The following is a description of a gene set: Transport of Mature Transcript to Cytoplasm studied in species Homo sapiens Human Gene Set: REACTOME_TRANSPORT_OF_MATURE_TRANSCRIPT_TO_CYTOPLASM, and this is the list of marker genes: CPSF1, RANBP2, NCBP2, U2AF1, DDX39B, THOC5, CDC40, FIP1L1, NUP43, CHTOP, NUP155, WDR33, NUP205, NXF2B, SARNP, SEH1L, NUP54, NUP160, SRSF4, NUP210, NXF1 (nuclear RNA export factor 1), U2AF1L4, POM121, NCBP1, RBM8A, NUP98, NUP62, THOC2, NUP35, NUP58, DDX39A, NUP42, NXF2, GLE1, SRSF7, NXT1, CASC3 (NCBI Gene Id 22794), POM121C, MAGOH, SRSF3, U2AF2, SRSF1, NUP133, CPSF4 (NCBI Gene Id 10898), NUP214, CPSF2, SRSF11, THOC3, CPSF3, NUP153, SRSF2, NUP88, DHX38, POLDIP3, NUP107, NDC1, SRSF6, THOC1, SRRM1, EIF4E, EIF4A3, RAE1, NUP93, SRSF9, THOC6, SLU7, SYMPK, ALYREF, NUP85, AAAS, UPF3B, THOC7, SRSF5, SLBP, RNPS1, NUP37, TPR, ZC3H11A, LUZP4, NUP50, NUP188, MAGOHB, FYTTD1, SEC13